Given this list of marker genes TDRP, BTLA, ZNF626, POU4F2, TM9SF3, FMNL3, UBA3, FAM200A, KLRC2, ARID1B, FAM24A, METTL15, RIOX2, GRK5, FAM98A, EEIG2, BCLAF1, CRIM1, BCKDHB, PAK3, TP63, RTP1, PLS1 (plastin 1), ZNF264, NRG2, ZDHHC21, MMAA, FOXI2, PLXNB3, RRAGC, PTPRQ, ALG10B, MAGEB1, MED1, ABHD5, CUL5, SLITRK6, TCAF2, LIN54, FREM1, KLRC1, DEFB118, MOCS1 (NCBI Gene Id 7931), ZCCHC9, PAN3, FNDC3A, ERBB4, NPY5R, LY75, MICU3, PCF11, KDM6A, PTGER2, NSD2, GABRA4, VHL, ANKRD12, GTF3C3, GUCY1A2, SMPDL3A, APPBP2 (NCBI Gene Id 10513), INSYN2A, RGS7BP, TSPAN3, TRIT1, PRDM5, C11orf54, MRTO4, PRKAR1A, RIN2, PANK3, LARGE1, ARRDC4, ZC3H12C, CUL4B, ZZZ3, ZKSCAN5, SREK1IP1, ADAM22, SLC5A5, ARID2, ITFG2, CAPZA1, NETO1, MSTN, DOCK5, PEBP1, HNRNPUL2, PTGFR, EXTL2, H1-0, ZNF830, IPCEF1, DMXL1, SHTN1, MYBL1, ELAVL4, TATDN3, C8A, FBXO40, ZFPM2, HIPK3, ERAP1, MBNL3, TFCP2L1, ANXA10 (NCBI Gene Id 51436), GABRA1, AEBP2, TTC14, MTMR4, PLCB1, EXOC5, CYP39A1, FOXG1, WNT5A, INO80D, NUP155, RALGPS2, IL6ST, RAB28, TANK (TRAF family member associated NFKB activator), IFT22, ZNF474, BPNT2, CREBRF, L2HGDH, PSD2, RHOA, GLCCI1, SATB1, AMER2, BRWD3, UPF2, SFPQ, MAP3K20, ITPR3, HTN1, LRIG1, DHX9 (DExH-box helicase 9), WDR26, COL5A2, ZNF761, PTPN3, GLS, NDFIP2, TRPC3, MASTL, ATP7A, DCT, G2E3, IAPP, LRRN1, TAFA2, RASA3, ERG28, ZNF805, ARIH1, SUZ12, FANCI, FAM117B, PTBP3, CTTNBP2, GALK2, VPS72, C2orf88, KALRN, BMP2, AAK1, EFNA5, KLF12, KBTBD6, HDDC2, BEND3, UBR2, MALRD1, FLRT1 (fibronectin leucine rich transmembrane protein 1), LIPH, ZC3H6, TRIM23, FAM72C, PHACTR2, CDHR3, KCNB1, MYD88, EIF4G3 (NCBI Gene Id 8672), FUT9, RYBP, SARNP, SLC16A4, STX17, COPG2, PRLR, TBR1, GMCL1, LZTS3, PRKAA1, PPP1CB, SAP18, YOD1, RPS6KB1, PCBD1, ETV3, ARHGEF33, THG1L, SLC25A21, PRR23B, CHRNB1, LPCAT2, SEL1L, HEATR1, MICAL2, IL20RA, DSE, PI4K2B, RGS9BP, KRR1, ZNF652, NAA25, SHCBP1, PIAS2, TNFSF11, MFSD14B, UBE2J1, SIX1, RICTOR, CCDC148, HNRNPU, TLE1 (TLE family member 1, transcriptional corepressor), A4GNT, SIKE1, SPOUT1, LRRC34, GPR65, DDX21, PALS2, DTNA, KBTBD7, PPP2R5E, DGKE, FAM72A, TC2N, SLC22A24, ACBD3 (NCBI Gene Id 64746), SLC13A1, NUBPL, STAG2, NDST3, PDE1C (phosphodiesterase 1C), CD109, NID1, PCNX1, LATS1 (NCBI Gene Id 9113), SEMA3A, DCDC2, RNF19A, CWC27, ZC3H12B, RPP14, PTPN4, TAGAP, MTMR10 (myotubularin related protein 10), RASGRP1, NCOA3, ADAT1, VEGFB, DDX19A, SLC35E4, PRP4K, MTUS2, SUPT20H, GBP7, SUDS3, GLRX3, ZCCHC14, NRIP3, SNAPC1, TRDMT1, ZNF530, SASH1, TNPO1, IKZF5, UNC80, ZNF12, CTNNA3 (NCBI Gene Id 50620), CLYBL (citramalyl-CoA lyase), SNX18, ZNF585B, LIN52 (lin-52 DREAM MuvB core complex component), DCUN1D5, TMEM170B, CFAP44, DNAJB4, TUT7, RIF1, LHX1, ABHD6, HTR1F, DUSP21, ANTXR2, NR3C1, NRXN1, CSPP1, LARP4B, DGKI, OSGIN2, PTPRZ1, THAP5, EIF5B, GTF2A1, ERG, ZBTB1, SELENOP, CHRNA5, DIAPH2, IL23R, PLCXD3, NR1D2, GTF2H3, ECRG4, SLC26A4, SNF8, BTBD7, FNIP1, UHMK1, PTEN, APPL1, CDK6, PLPP6, USP15, COMT, FBXL3, DENND2A, CDH12, ITPRID2, CD2AP, RNF144B, DCAF4L1, LRP2, ADARB1, GRIK2 (NCBI Gene Id 2898), USP46, RAMAC, GUCY1A1, IFNGR1, CERKL, C5orf24, NOVA2 (NOVA alternative splicing regulator 2), FAM72B, DSP, EEA1, PDK4, PIP5K1B (phosphatidylinositol-4-phosphate 5-kinase type 1 beta), SLC25A15, TRAFD1, CLEC4D, LRP11, ADGB, STXBP3, NTNG1, PRRX1, RIMKLA, DHX33, PSD3, CARF, CHRM3, HTN3 (histatin 3), B3GALT5, SLAIN2, TMEM67, RRAS2, YAF2 (NCBI Gene Id 10138), TTYH2, ZNF563, TCF12, VSTM2A, TBX18, STEAP2, GSE1, TRPS1, ATRX, ALYREF, FANCD2, PCDH11X, PIK3CA, PLEKHB1, TMEM30A, TOP1, PEDS1, TYRO3, PCDH9 (protocadherin 9), MID1, TSHR, IL17RA, ST18, SLC4A7, OGG1 (NCBI Gene Id 93577), CATSPERE, HSD17B13, UNC13C, ATP2B1, ME2, SPRY2, CFAP90, PHYHIPL, CBFA2T2, ZNF829, GABRG2, PPARGC1B, PAK2, RNF128, SELENOS (NCBI Gene Id 55829), SLC25A24, FAM72D, SLC35B4, EPHA5, MAGEB4, STATH, OLIG2, KCNQ5, PLAG1, PLEKHA1, TMEM106B, GCNT1, ATP8A1, DPY19L4, RSPH3, DGKH, CPEB3, PHIP, ZNF507, FABP7, HYPK, ZBTB20, SCAF11, GINS1, PEX13, ARHGEF3, PXMP4, OXR1, TDRD6, HSD17B12, TAC1, HSPA13, PRKG2, SETD9, BLOC1S4, SGIP1, BNIP1, SEMA5A, AP1G1, ADAM20, GPR158, MAP3K2, SCP2, ZNF585A, NHS (NCBI Gene Id 907), HNRNPD, TIPARP, SF3B3 (NCBI Gene Id 9661), SOD2, EPCIP, MTX3, IVD, PROSER2, RBM12, ZNF519, FAM98B, LMNB1, SMAP1, IPP, DAPP1, PCDH11Y, SSTR2, ZNF385B, PRUNE2, PCBP2, TSPYL6, CPNE8, DCC (DCC netrin 1 receptor), EXO1, here is a description of the gene set: Human Gene Set: MIR4482_3P species: Homo sapiens from publication Chen Y, Wang X (PMID 31504780) Genes predicted to be targets of miRBase v22 microRNA hsa-miR-4482-3p in miRDB v6.0 with MirTarget v4 prediction scores > 80 (high confidence targets).